The following is a description of a gene set: Human papillomavirus (HPV) virus-like particle (VLP) vaccines were recently licensed. Although neutralizing Ab titers are thought to be the main effectors of protection against infection, early predictors of long-term efficacy are not yet defined and a comprehensive understanding of innate and adaptive immune responses to vaccination is still lacking. Here, microarrays were used to compare the gene expression signature in HPV-16 L1 VLP-stimulated PBMCs from 17 vaccine and 4 placebo recipients before vaccination and 1 mo after receiving the second immunization. Vaccination with a monovalent HPV-16 L1 VLP vaccine was associated with modulation of genes involved in the inflammatory/defense response, cytokine, IFN, and cell cycle pathways in VLP-stimulated PBMCs. Additionally, there was up-regulation of probesets associated with cytotoxic (GZMB, TNFSF10) and regulatory (INDO, CTLA4) activities. The strongest correlations with neutralizing Ab titers were found for cyclin D2 (CCND2) and galectin (LGALS2). Twenty-two differentially expressed probesets were selected for confirmation by RT-PCR in an independent sample set. Agreement with microarray data was seen for more than two-thirds of these probesets. Up-regulation of immune/defense response genes by HPV-16 L1 VLP, in particular, IFN-induced genes, was observed in PBMCs collected before vaccination, with many of these genes being further induced following vaccination. In conclusion, we identified important innate and adaptive response-related genes induced by vaccination with HPV-16 L1 VLP. Further studies are needed to identify gene expression signatures of immunogenicity and long-term protection with potential utility in prediction of long-term HPV vaccination outcomes in clinical trials. Genes down-regulated in peripheral blood mononuclear cell stimulated vs unstimulated in young adults (18-25) after exposure to HPV-16 L1 VLP, time point 0D. Comment: List of Genes induced by VLP directly, independently of vaccination (p<0.05 and FC>1.30) from publication García-Piñeres AJ, Hildesheim A, Dodd L, Kemp TJ, Yang J, Fullmer B, Harro C, Lowy DR, Lempicki RA, Pinto LA (PMID 19155521) species: Homo sapiens Human Gene Set: GARCIA_PINERES_PBMC_HPV_16_L1_VLP_AGE_18_25YO_STIMULATED_VS_UNSTIMULATED_0DY_VACCINATION_INDEPENDENT_DN, and this is the list of marker genes: ALDH1A1, PDPN (NCBI Gene Id 29912), PLEK2, HPCAL4, NINJ2, ZFYVE9, TNS1, CADM1, PAPSS2, STXBP1, CLCA1, RCAN3, KIR2DS5, CASP8AP2, MMP2, SCD, ZNF124, CRYGD, RARRES1, HTR2C, MARCO, CHIT1, RARG, CHRNA1, TRAIP (TRAF interacting protein), FOLR2, LMO1 (LIM domain only 1), SLC2A11, SERPINF1, SH3BP4, TREM2, GPX3, CEP250, CDK6, INSR, LAMC2, AKR1B10, CPM, IMPA2, BEX3, IL5RA, SNCA (synuclein alpha), GLIPR1, C5, TNNI2, CHRM4, DPEP2, HS3ST2, ALDH3A2, CAV3, APOE, SORL1, HTT, PTGES, A2M, BCL11B, GPRC5B, PFKFB1, EIF1AX, PELI2, MRC2, OSGEPL1, CLIC5, NRCAM, RNASE4, MMP8, UBASH3A, OAT, ABCC3, APOC1, ITGAV, NPL, CHRNG, DTWD1, ENOSF1, CXXC4, CRHBP, SLC26A2, SELENOP, CYP27A1, ENC1, ITGAE, MARCHF6, PMS2, AK1, HSD17B4, CELSR1, SDS, WNT7A, PLXNC1, HAMP, GSDME, CD96 (CD96 molecule), COL1A2, IRS2, HOXD11, FGF9, EDA2R, F13A1, HOXC11, PLTP, TRIM16, NQO1, FABP3, APOC2, NPFFR1, ATXN1, CYP2C18, PLIN2, EPAS1, SCML1, SHH, NDRG2, FABP4, EFNA5, PRKG2, CTSG, LEP, CD9, TG, ITIH3, PLXNA1, KEL, CD8B, TSPAN5, GCM1, KDELR2 (KDEL endoplasmic reticulum protein retention receptor 2), NEO1, ALDH7A1, SSR3, KCNMA1, TFCP2L1, ABO, STEAP1, GLT8D2, SMAD6